Given this list of marker genes NRXN2, NRXN1, NLGN2, SLITRK3, ZDHHC12, here is a description of the gene set: Human Gene Set: GOBP_GEPHYRIN_CLUSTERING_INVOLVED_IN_POSTSYNAPTIC_DENSITY_ASSEMBLY The clustering process in which gephyrin molecules are localized to distinct domains in the postsynaptic density as part of postsynaptic density assembly. Gephyrin is a component of the postsynaptic protein network of inhibitory synapses. studied in species Homo sapiens